Given this list of marker genes Dnajc6, Ptpn1, Nudc, Timm13, Sec61a2, Tspo2, Pex7, Tmem97, Ttc21a, Trp53, Rdx, Rab8b, Romo1, Setd2, Kif1b, Lrrc7, Dctn1 (NCBI Gene Id 13191), Pcdhga3, Ergic2, Vps26b, Spg11 (SPG11, spatacsin vesicle trafficking associated), Rab21, Reps1, Ssna1, Ift88, Ift70a2, Wdr19, Nsg1, Nop9, Fhip1b, Kpna4, F8a (NCBI Gene Id 27589), Becn2, Ubb, Syvn1, Ddx39b, Dennd1b, Alms1, Atp6v0d2, Trappc3, Dynll1 (dynein light chain LC8-type 1), Scfd2, Rph3al, Cd63, Tacc2, Slc30a2, Stx1b, Chmp4b, Lipa, Pink1, Dync2i2, Oaz2, Lmf1, Commd1, Xpo1, Mia3, Tmem87a, Ap5m1, Exoc6, Arf6, Tnpo1, Mak, Rab11fip4, Akt1, Nedd4, Lamp2, Ap3s2, Kifc2, Intu, Marcks, Bmp4, Spast, Ccdc93, Slc48a1, Ranbp6, Tmem201, Rims2, Arl5a, Hook1, Bltp1, Bloc1s5, Hm629797, Rapgef3, Srpra, Gripap1, Nup88, Exoc4, Caly, Tsc2, Lyset, Trappc11, Septin8, Sec31b (NCBI Gene Id 240667), Copb2, Pom121, Vamp4, Snx9, Zfand2b, Actn4, Peg12, Lamp1, Kpna1, Rae1 (ribonucleic acid export 1), Derl1, Golt1b, Atf2 (activating transcription factor 2), Mapk3, Trappc2l, Timm9, Map1a, Aktip (AKT interacting protein), Spg7, Copa, Snx2, Ift22, Park7, Lyst, Cdk1 (cyclin dependent kinase 1), Kif16b, Rbm4, Alyreffm7, Nup93, Ubac2, Entr1, Pafah1b1, Dync2h1 (NCBI Gene Id 77047), Sfpq, Tacc3, Tacc1, Rps15, Ap3m1, Ywhah, Ehd3, Sytl5, Snx8, Reep2, Anxa8, Trarg1, Syndig1, Hps4, Osbpl2, Atg16l1, Pex13, Ehd1, Pla2g4e, Zfand1, Nup107, Ap1s2, Sec24b, Lcp1, Herpud1, Rab31, Whamm, Actn2, Prkag1, Spag9, Klc1, Stard4, Ndrg4 (N-myc downstream regulated gene 4), Sec61a1, Ppm1a, Stx2, Hgsnat, Ap3b1, Clec16a, Rilpl1, Ranbp17, Ahctf1, Mcm3ap, Vps35, Tbc1d10c, Mvb12a, Flot2, Vps37a, Timm10, Chmp5, Borcs6, Cfl1, Vti1a, Alyreffm1, Nxf2, Creb3l2, Trappc2, Pex1, Arhgap8, Pcm1, Nrde2, Ap2a2, Ehd4, Agap2, Tmed1, Appl2, Ighm, Tecpr2, Washc2, Psap, Bicdl1, Plekha3, Alyref2, Cdan1, Camk1, Mdn1, Mpdz, Lrp1, Copg1, Snord60, Tmed10-ps, Ice1, Cltb, Pkia, Hps6, Kxd1, Timm23, Zc3h11a, Vps37d, Yod1, Erlec1, Sirt7, Exph5, Tmem230, Mppe1, Ei24, Tmcc1, Sort1, Kif3a, Snx4, Stxbp2, Chmp1b (charged multivesicular body protein 1B), Wdpcp, Ufm1 (NCBI Gene Id 99652), Akirin2, Thoc7, Was, Dyrk1a, Ube2g2, Ramp1 (receptor (calcitonin) activity modifying protein 1), Ccdc88c, Emp2, Pex12, Ift27, Chmp1b2, Anp32a, Rbm15b, Rbm10, Ptpn5, Ppp3r1, Plekhm2, B3gat3, Xpo6, Scamp3, Ncoa4, Msn, Alyreffm9, Arl4d, Umod, Sec22c, Bmpr2, Tram1, Stx1a, Map1b, App, Rpgr (NCBI Gene Id 19893), Numa1, Tuba1a, Ipo9, Kif5c (NCBI Gene Id 16574), Rab17, Tbc1d17, Lmx1b, Fermt1, Gm14461, Lman1l, Nup50l, Kpnb1, Cep120, Hook2, Bloc1s1 (NCBI Gene Id 14533), Kpna3, Bmpr1a (bone morphogenetic protein receptor, type 1A), Ssb, Pkd1, Stk3, Uaca, Apba1, Cabp1, Rims1, Map2k1, Tbc1d5, Clip1, Vipas39, Rsrc1, Fbxo22, Kif5a, Arl14, Grip1, Stk4, Rabl3, Usp9x (ubiquitin specific peptidase 9, X chromosome), Thoc1, Stbd1, Chp1 (NCBI Gene Id 80510), 5730455P16Rik, Prickle1, Gga1, Nup214, Snx18, Cilk1, Grn, Bcl2l1, Nup188, Vps36 (NCBI Gene Id 76372), Cnih4, Vps28, Clip3, Reep1, Pcsk9, Sec63, Snx5, Arl1, Dync1li1, Sytl2, Alyreffm6, Washc4, Baiap3, Snx7, Spag17, Clu, Ift172, Ap1ar, Srp54a, Dmap1, Sprn, Gramd1c, Pttg1ip2, Poldip3 (polymerase (DNA-directed), delta interacting protein 3), Dennd2a, Ube2i, Abcd1, Ubr5, Vapa, Myo1d, Ddx39a, Trappc13, Rab5b, Thoc2, Strit1, Ddx5, Nup42, Nefl, Nsun2, Rbsn, Cog3, Pex6, Kif20b, Myh10, Adam10, Abcd4, Tmem106b, Camsap3, Arl5c, Bsn, Slc30a6, Vps13b (vacuolar protein sorting 13B), Elavl1, Hspa9, Chchd4, Tfg, Mlc1, Tmem30a (NCBI Gene Id 69981), Gsk3b, Rab11b, Src, Tbc1d20, Prkcd, Rab9b, Chmp2b (charged multivesicular body protein 2B), Madd, Ywhab, Hsbp1, Stau1, Nup54, Cope, Golga2, Trappc10, Ccdc88b (NCBI Gene Id 78317), Fez1, Fchsd1, Stx3, Fnbp1l, Rangrf, Becn1, Slc66a2, Stx7, Btbd8, Sec24d, Ranbp1, Gfap, Ap3m2, Tmem30b, Kpna6, Borcs5, Ipo11, Bbs5, Nmd3, Rangap1, Agt, Tmem129, Mon1b, Rcsd1, Rbm33, Mdfic, Tmem94, Actr2, Syne1, Ubxn6, Vps33a, Sun2, Sem1, Pex10, Vps26c, Gas1, Nup133, Acacb, Scfd1, Pex5l, Slu7, Arf2, Xpo7, Xpo4, Ipo5, Ptk2, Rabggtb, Nutf2-ps2, Cul3, Notch1, Cln3, Tmed3, Sp100, 1700017N19Rik, Khdrbs1, Mlph, Fam53c, Dnajc27, Pla2g3, Pick1, Rab23, Cry2, Cln5, Nefh, Chmp4c, Vps26a (VPS26 retromer complex component A), Mon2, Bbs1, Rab19, Egr2, Ngfr, Alyref, Os9, Ranbp2, Gprasp1, Cdc42bpa, Ap2a1, Ap1g2, Copz2, Rftn1, Eps15l1, Rhbdd1, Abca2, Smurf1, Alyreffm14, Vapb, Ifng, Lmnb1, Hikeshi, Hcls1, Sirt6, Trim58, Rtn2, Tmem50a, Bloc1s4, Kif1a, Fuz (fuzzy planar cell polarity protein), Rnf126, Cd24a, Klhl12, Klc3, Desi1, Tnpo3, Angpt1, Dync2li1, Ift52, Cpsf6, Ddx19a, Ap1g1, Rab43, Ap4m1, Mlxip (MLX interacting protein), Pex16, Gramd1a, Ap4b1, Vps54, Yif1a, Zfp384, Nutf2-ps1, Tmed11, Yif1b, H13, Fmr1, Capn10, Tmed2, Bmp2, Vps39, Ift122, Rbm22 (RNA binding motif protein 22), Stam, Svip, Ehd2, Cog7, Prkn, Npm1, Uso1, Snx12, Eipr1, Copg2, Scap, Coro7, Dync1i2, Cryab, Pex19, Srp54c, Plekhf1, Ube2j1, Evi5, Tardbp, Alyreffm10, Pik3c3, Mapk1, Mfsd1, Pdcd6, Hspa4, Alyreffm3, Mmp12, Agtpbp1, Thoc3, Sel1l, Trim46, Kifc1, Nrbp1, Eif3e, Rufy3, Agtr2, Sh3glb1, Tmem87b, Rffl, Tm9sf4, Rab7, Mapk14 (mitogen-activated protein kinase 14), Trappc12, Mecp2, Fam76b, Med1 (NCBI Gene Id 19014), Bbs12, Igf2r, Zfyve9, Dennd10 (NCBI Gene Id 67894), Dennd3, Strada, Clta, Klhl20, Cd74, Ap5s1, Sec22b, Xpo5, Cdkn2a, Nus1, Kif2a, Dop1b, Vti1b, Clmn, Mapk8, Ncbp1, Smo, Yipf5, Ap3s1, Aspscr1, Faf2 (Fas associated factor family member 2), Slc25a20, Ccdc38 (coiled-coil domain containing 38), Rabggta, Vps33b, Derl3, Appl1, Ift25, Map2, Mtmr2, Dync1i1, Sec61b, Trim23, Fam91a1, Kif17, Nup43, Nf1, Steep1, Cdh1, Hspa8, Hgs, Kif3b, Vamp3, Snx3, Arl3, Snx32, Map2k2, Washc5, Ranbp3l, Fam53b, Tmem50b, Copz1, Srsf3, Mtm1, Rab2a, Lsg1, Hdac6, Epg5, Tsc1, Srsf10, Scyl2, Atg5, Wasf1, Nup98, Nos3, Rhot2, Ap2m1, Sec24c, Eny2, Pln, Kif13a, Heatr5a, Tpcn2, Mtmr4, Ift70a1, Ezr, Cpt2, Vps52, Gosr1, Chrm1, Sgsm2, Ankrd27, Pura, Ptpn23, Bicdl2, Fmn2 (formin 2), Atp6ap1, Tmed5, Zpr1, Dennd5a, Ncbp3, Arl11, Abcd2, Pkig, Stx8, Wdr35, Riok2, Hnrnpa2b1, Ptgs2, Stx19, Nxf7, Eif6, Kif21a, Snx11, Reps2, Relch, Akap8l (A kinase anchor protein 8-like), Phip, Stk11, Pola2, Ergic3, Cdkn1a, Arv1, Nup155, Snx33, Txn1, Stx18, Fabp3, Large1, Atp6v0d1, Vps8, Rab7b, Oaz1, Pik3r4, Arf3, Dtx3l, Ppp1r12a, Six2, Derl2, Plekhf2, Tub, Rab29, Pax6, Mtch2, Tgfbrap1, Hspa1a, Ddx19b, Mapt, Nup160 (NCBI Gene Id 99202), Ap3d1, Wdr81, Brca1, Pcnt, Slc51b, Dnajc13, Agap3 (ArfGAP with GTPase domain, ankyrin repeat and PH domain 3), Nemf, Rabl2, Rab8a, Snx31, Rint1, Tbc1d23, Sec16a, Ramp2, Hrc, Rufy4, Mkks, Tnfrsf1a, Gnptab, Stx6 (syntaxin 6), Rab4b, Rab18, Kcnip3, Arfip1, Xpot, Gbp4, Map6, Tram1l1, Ing1, Napg, Prkcz, Pex14, Ntn1, Fam53a, Klc2, Ssx2ip, Snx1, Ift20, Bcl3, Bcr, Syt4, Borcs7, Sh3tc2, Ift46, Trappc5, Cert1, Trappc6b, Zfyve16, Igtp, Yipf7, Hap1, Ap1s1, Tomm22, Efcab7 (EF-hand calcium binding domain 7), Bves, Bicd2, Lrp2, Erc1, Lca5l, Vps41, Prpf4b, Pex26, Arfip2, Sec22a, Tomm20 (translocase of outer mitochondrial membrane 20), Ptpn11, Ift80 (intraflagellar transport 80), Chtop, Pcid2, Gle1, Inpp5f, Mtch1, Kif1c, Sar1a, Shh, Dennd1a, Anp32b, Tamalin, Edem2, Hnf4a, Anxa2, Sqstm1, Pom121l2, Rab6a, Arl5b, Ift43, Rab14, Vps13d, Gli3, Uevld, Nxt1, Psen1, Armcx3, Bag3, Insig1, Kcnq3, Frat1 (NCBI Gene Id 14296), Magel2, Ect2, Ap4e1, Snx6, Map6d1, Laptm4b, Gckr, Wdr91, Aup1, Ranbp3, Sec23a, Chmp7, Arcn1, Ank1, Rab13, Grk3, Tmem108, Bin1, Rab28, Diaph3, Rab38, Vps13a (NCBI Gene Id 78932), Edem1, Vps18, Ier3ip1, Surf4, Rab32, Frat2, Bicd1, Vps11, Gpihbp1, Unc93b1, Usp7, Ptpn22, Mavs, Gak, Als2cl, Cttn, Glp1r, Vps51, Dlg2, Dop1a, Hsp90b1, Htatip2, Ift70b, Tbc1d10a, Nsf, Ero1b, Hnrnpa1, Scg5, Appbp2, Nherf1, Sorl1, Tmem41b, Slc35d3, Sys1, Tex261, Nup153, Rasl2-9, Uhmk1, Ap1s3, Mon1a, Nup210, Nefm, Ap3b2, Epm2a, Itsn1, Stx4a, Rab35, Cse1l, Emd, Nfatc3, Serac1, Ift81, Vps13c, Nxf1, Lrp6, Arl4a, Hyou1, Kpna7, Ube2o, Arf1, Arf5, Nr4a1, Nup62, Stx17, Uchl1, Itsn2, Washc1, Fcgr2b, Nde1, Rita1, Vcp, Sec24a, Il6, Sec13, Nup58, Ift74, Rab5a, Yipf6, Tram2, Sfn, Copb1, Atp2a3, Rab9, Sdad1, Syne2, Tmed7, Snf8, Mcoln1, Hif1a, Irgm1, Pik3r1, Dhx9, Txnip, P4hb, Pabpn1, Pik3r2, Tom1, Nup85, Ipo7, Als2, Snapin, Rab10, Akap1, Cd81, Ptpn14, Alyreffm5, Ufd1, Zic1, Chmp2a, Hps3, Trappc4 (NCBI Gene Id 80545), Alyreffm8, Rhot1, Picalm, Trim27, Cnih2, Ap1m2, Ndfip1 (Nedd4 family interacting protein 1), Tap2, Ifi27, Ccdc186, Sod1, Myrip, Vamp2, Vta1, Sptbn5, C9orf72, Pttg1ip, Nup37, Arhgap1, Ap5z1, Lca5, Myo7a, Tnnt2, Lamtor1, Oaz3, Reep6, Ykt6, Rabgef1, Rgs14, Daw1, Abcc2, Phb2, Vps50, Trip11, Phax, Spag5, Actr10, Sgpp1, Snx13, Leprot, Asph, Syne3, Terf2, Snap25, Cchcr1, Vps37b, Kif28, Slc30a4, Nup35, Sec62, Gga3 (golgi associated, gamma adaptin ear containing, ARF binding protein 3), Syk, Cpt1b (NCBI Gene Id 12895), Traf3ip2, Bet1, Tbc1d13, Napb, Itgb1, Pex2, Rab24, Fyttd1, Rab1a, Ldlr, Sumo1, Chmp6, Abcd3, Arf4 (ADP-ribosylation factor 4), Star, Wipi1, Snupn, Tap1 (transporter 1, ATP-binding cassette, sub-family B (MDR/TAP)), Prkd1, Hspa5, Pml, Thoc5 (THO complex 5), Trim28, Ttc21b, Stx5a, Inpp4b, Fyco1, Rilp, Kpna2 (NCBI Gene Id 66474), Ipo13, Tmed10, Tmed9, Lrba, Rph3a, Bcap31, Ccdc88a, BC048507, Rilpl2 (Rab interacting lysosomal protein-like 2), Selenos, Tlk1 (tousled-like kinase 1), Bloc1s2 (NCBI Gene Id 73689), Stau2, Preb, Mdm2, Atp2a1, Napa, Grip2, Abcg1, Camk4, Rassf9, Chp2, Tmed6, Ap1m1, Wipf1 (NCBI Gene Id 98855), Pex3 (NCBI Gene Id 80463), Ep300, Cideb, Tek, Stx12, Plk3, Washc3, Stxbp3, Rasgrp1, Hps5, Nxt2, Ipo4, Mrln, Pgap1, Trappc6a, Seh1l, Cdc42, Snx10, Casc3, Lrrk2, Eif4a3, Yipf4 (NCBI Gene Id 67864), Ccdc91, Ctdspl2, Myo1c, Cltc, Drd1, Hps1, Bet1l, Slit1, Gramd1b, Trak2, Kif5b, Sytl4, Scarb2, Rab11fip3, Rab12, Use1, Dab2, Adar, Cd36, Mapk8ip3, Tanc2, Tnnc1, Hhex, Lman2, Fhod1, Ldlrap1, Nfkbia, Snx27, Lonp2, Exoc6b, Trim37, Ap5b1, Cdkn1b, Atp2a2, Ripor1, Traf3ip1 (NCBI Gene Id 98598), Lman2l, Hsp90ab1, Cited1, Cluap1, Alyreffm4, Lmnb2, Arl4c, Alkbh5, Stx11, Tmco6, Zc3h12a, Jak2, Cmtm6 (NCBI Gene Id 67213), Sybu, Abca12, Cep290, Prkcq, Flna, Mylk2, Fbxw11, Abra, Snx17 (sorting nexin 17), Kcnq2, Samm50, Magoh, Nf2, Sytl1, Micall2, Bmal1, M6pr, Rufy1, Dock7, Prr5l (proline rich 5 like), Vps29, Vps35l, Rbm8a, Nup50, Sec23b, Bbs7, Bloc1s3, Myo19, Nolc1, Mapk15, Clba1, Vps4b, Lmna, Sec61g, Chml, Chm, Timm29, Pdcd5, Hdac3, Tmem167, Vps4a, 1700009N14Rik, Rab27b, Wdr11, Ndc1, Npc1, Sun1, Leprotl1, Bloc1s6, Gbf1, Agk, Dennd1c, Ipo8, Sytl3, Trappc2b, Dync1h1, Borcs8, Thoc6, Aftph, Thoc2l, Pef1, Kpna2rt, Chmp1a, Arl8b, Syt7, Tomm20l, Rhobtb3, Stat3, Prepl, Ddx25, Snx16, Adipoq, Axin1, Mgrn1, Agbl4, Atxn1, Chmp3 (charged multivesicular body protein 3), Myo5b, Wls, Magohb, Hnrnpu, Acap2, Lmtk2, Pheta2, Alyreffm2, Ap2b1, Hspa12a, Ankrd54, Ankle1, Arl6, Cryaa, Sorcs2, Nutf2, Stx16, Vps25 (NCBI Gene Id 68583), Myo10 (NCBI Gene Id 52514), Ankrd50, Tbc1d10b, Hyal2, Erp29, Arfrp1, Cep131, Atp13a2, Rab22a, Trmt10b, Dtnbp1, Apod, Ltv1, Trappc1, Lman1, Tsg101, Tmed4, C2cd5, Iws1, Malt1, Dynlt2b, Rab34, Vps16, Vps53, Ndp, Ramp3, Gcc2, Dnm1l, Trappc9, Kif21b, Atp9a, Tgfb1, Rab11a, Pip4k2a, Il33, Tnpo2, Bltp3b, Cracr2a, Spire1, Pdcd5-ps, Arl8a, Golt1a, Rnf139, Dync2i1, Myo5a, Scp2, Ap1b1, Ncbp2, Wipf3, Zdhhc2, Coro1c, Stradb (NCBI Gene Id 28142), Atg14, Rpain, Scrib (scribbled planar cell polarity), Wnk1, Sec31a, Wasl, Tomm70a, Ift56, Xbp1, Micall1, Zw10, Nsg2, Ier3, Bach2, Vps37c, Spire2, Rab6b (NCBI Gene Id 77488), Sar1b, Lep, Trappc3l, Slc30a3, Hsp90aa1, Bard1, Cdx2, Dbn1, Pikfyve, Rab20, Vps45, Ift57, Rgp1, Ric1, Arhgap44, Akap13, Sarnp, Nme7, Cdk5, Plekha8, Ran, Dst, Rab5c, Ahcyl1, Ppfia2, Osbp, Ap2s1, Ndufa13 (NADH:ubiquinone oxidoreductase subunit A13), Kifap3, Ppp1cc, Bcap29, Sec16b, Mlx, Calr, Lzts2, Cwh43, Stxbp1, Pdcd10, Acd, Pheta1, Tmem53, Ndel1, Sec61bl, Kifbp, Timm22, Heatr3, Neto1, Plekhj1, Ergic1, Ccdc22, Nxf3, Mreg, Abca1, Fgf9 (fibroblast growth factor 9), Supt6, Eps15, Ywhae, Lhcgr, Coro1a, Mia2, Neurod1, Zmpste24, Dpy30, Pex5, Afg2b, Anp32-ps, Hspb1 (NCBI Gene Id 15507), Tpr, Nup62cl, Tenm1, Ank3, Eif4enif1, Irgm2, Prkaca, Ift140, Jup, Trak1, Ppp3ca, Six3, Snx30, Tbc1d14, Nol6, Gga2, Laptm5, Npc2, Ap4s1, Timm44, Slc17a9, Rab1b, Ythdc1, Alyreffm11, Htt, Eif4e, Hook3, Plekhm1, Nploc4, Arhgap21, Gas6, Ankfy1, Akap5 (A kinase anchor protein 5), Mgarp, E2f3, Aaas, Heatr5b, Gper1, Rhob, here is a description of the gene set: The directed movement of substances within a cell. Mouse Gene Set: GOBP_INTRACELLULAR_TRANSPORT studied in species Mus musculus